Given this list of marker genes MMP9, MIGA2, MGARP, TRMT10B, TIMM10, LYRM2, TP73, SLC25A33, MLLT11, CTCF, AKT3, SDHAF4, BCS1L, TIMM50, NDUFS2, MTX3, COA4, PRDX3, HRK, CHCHD7, MAPT, PLEC, NOL3, CHCHD6, HSPA1A (heat shock protein family A (Hsp70) member 1A), NME3, CERT1, USP30, BNIP3, SIVA1, NDUFB2, POLG, INF2, IFIT2, RAB5IF, EDNRA, SURF1, NDUFB3, HIP1R, HSPA9, VDAC2, MAN2A1 (NCBI Gene Id 4124), RAB32, METTL4, CLUH, MIEF1, NDUFAF2, GPER1, DNAJA3, OMA1, CEP89, LONP1, NDUFS7, RTL10, NDUFAF4, MT-ND5, COA5, BCL2L1, LETM2, SIRT4, ATG3, MFF, MOAP1, MTFR2 (mitochondrial fission regulator 2), SUPV3L1, MIR17, NDUFA6, MARCHF5, GSK3A, MICOS13, P2RX7, EYA2, BNIP3L, TYMP, HK2, TMEM223, BCL2L10, DDHD2, PHB2, TOMM7, TAFAZZIN, CLPP, UQCC4, HIGD2A, CCAR2, RHOT1, SDHAF2, COX10, ACAA2, NDUFC2, KDR, COA3, NECTIN2, DNAJC11, TOMM40, SDHAF1, TRIAP1, THG1L, RRM1, TMEM242 (transmembrane protein 242, NCBI Gene Id 729515), AIFM2, UQCC3, BCL2L13, VPS54, HDAC6, SMAD3, HAX1 (NCBI Gene Id 10456), BCL2L2, TIMM8B, UQCC1, FXN, SLC25A46, TFAM, CRYAA, MT-ND1, OXA1L, FANCG, PLD6, PISD, CXADR, LETMD1, AP3B1, TWNK, MTFP1, SPG7, BIK, HMGCL, MIURF, NDUFAF1, SDHAF3, TOMM22, SIRT7, AGK, YME1L1, CYRIB, NDUFS4, RALA, CHCHD3, STOML2, MGME1, MTX2, GHITM, ARMCX3, SELENON, FAM3A, PRKACA, TOMM6, MIR29B1 (NCBI Gene Id 407024), SLC25A31, STAT3, LETM1, APOO (NCBI Gene Id 79135), STMP1, MTCH2, TIMM9, PGAM5, COX7A2P2, ECSIT, TIMM13, CEBPA, ATP23, GGCT, ATP5F1D, UQCRFS1, TRABD, MYH14, AGTPBP1, VAT1, ATAD3C, WDR81, PARL, MYO19, AIFM1, COX7A1 (NCBI Gene Id 1346), PPP2CB, DDHD1, DCN, SPATA18, MIR29A, COX18 (NCBI Gene Id 285521), FIS1, TMEM14A, RCC1L, PPIF (peptidylprolyl isomerase F), MIGA1, BMF, UQCC2, SCO1, MFN1, RRM2B (NCBI Gene Id 50484), JTB, TIMM22, PRIMPOL, MICOS10, VPS13C, COL6A1, FUNDC1, MCL1, SMIM20, SLIRP, GDAP1, BID, TIMMDC1, ATP7A (ATPase copper transporting alpha), GOLPH3, WASF1, MTM1 (myotubularin 1), TOMM20, TMEM135, HIGD1B, NDUFAF6, PIF1, HTRA2, FMC1 (formation of mitochondrial complex V assembly factor 1 homolog), GCLC, TMEM186, DMAC2, COX17, ATAD3B, PEX5, SFN, MIR29C, OPA3, PHB1, MT-ND4, POLDIP2, IMMT, MIEF2, MAIP1, MTX1, IGF1, BCL2A1, AFG3L2, BBC3, PET117, SSBP1, EP300, GBA1, PIM2 (Pim-2 proto-oncogene, serine/threonine kinase), FEZ1, SLC25A6, TNFSF10, CNTNAP1, FAM162A, PRMT6, CLU, LMNA, STPG1 (sperm tail PG-rich repeat containing 1), TERT, ATAD3A, ERBB4, RAB38, COX16, CAV2, NOA1, CAMKMT, IER3, MTFR1L, NDUFS3, SAMM50, TEFM, COA6, NDUFS1, NIPSNAP2, BAX, IRGM, ROMO1, SLC35F6, ATPAF1, RAP1GDS1, DMAC1, STOX1, PRELID1, TMEM126A, TIMM21, PPARGC1A, HIGD1C, THEM4, TP53, GABPB1 (GA binding protein transcription factor subunit beta 1, NCBI Gene Id 82963), MT-ND6, PYCARD, MTFR1, AKT1, TOMM5, VPS35, CHCHD10, GPX1, COA1, PID1, TIMM29, MUL1, MFSD14A, BLOC1S2, UQCC6, MARCKS, UQCC5, SCO2, EPM2A, SESN2, ACAD9, SOD2, DNA2, PET100, SIRT5, MSTO1, MFSD8, ENDOG, BCL2L11, TIMM8A (translocase of inner mitochondrial membrane 8A), CHCHD2, PNPT1, LIG3, SLC30A9, TACO1, PPM1K, IMMP2L, TMEM11, BCL2, BAD, POLG2, CALM3, MCU, AURKA, ABCC9, LYRM7, SLC25A36, MTCH1, OPA1, CIBAR1, MPV17, PRKN, SPATA19, HIGD1A, AFG1L, MPV17L, NDUFS8, C11orf65, ARHGAP11B, BAK1, RAB3A, NDUFS5, SLC25A4 (solute carrier family 25 member 4), COA8, APOOL, NDUFAF5, CAMK2A, COX19, ATP5IF1, LRRK2, PLSCR3, STAT2, GSK3B, NAIF1, PDE2A, ADCK1, PINK1, NDUFAF3, TOMM70, TMEM70, HSD17B10, PLAUR, SPIRE1, PUM2, PPARG, HIGD2B, PMAIP1, NEURL4, NDUFS6, PTCD2, PSMD10, NDUFAF7, COX20, TIMM10B, IFI6, PANK2, SQSTM1, PARK7, HGF, TFRC, TTC19, NDUFA13, COX7A2L, NUBPL, ATP13A2, SLC25A5, TOP3A, HSPD1, EDN1, ZNF205, CHCHD4, UCP2, SNCA, PARP1, ALKBH7, SHARPIN, NPTX1 (NCBI Gene Id 4884), COX7A2, ZDHHC6, TMEM126B, GCLM, VPS13D, ATPAF2, FBXO24, ATF2, MT-ND2, FZD9, EPAS1, NOS3, KIF28P, POLRMT, DNM1L, BOK, COX14, SLC9A1, MFN2, NDUFAF8, DAP3, HUWE1, LIPA, RHOT2, CLN8, PYROXD2, MEF2A, VPS13A, ATP2A1, RALBP1, RAB29, FASTKD3, FOXRED1, TMEM102, MICU1, here is a description of the gene set: A process that is carried out at the cellular level which results in the assembly, arrangement of constituent parts, or disassembly of a mitochondrion; includes mitochondrial morphogenesis and distribution, and replication of the mitochondrial genome as well as synthesis of new mitochondrial components. Human Gene Set: GOBP_MITOCHONDRION_ORGANIZATION species: Homo sapiens